Given this list of marker genes CHRNA4, CHRNB3, CHRNA1, CHRNA2, CHRNB4, CHRNA9, CHRNA6, CHRNB2, CHRNA5, CHRNA3, CHRNA7, here is a description of the gene set: Postsynaptic acetylcholine receptors mediate Ca2+ currents that may be involved in the facilitation of long term potentiation (LTP). species: Homo sapiens Reactome Pathway: Highly calcium permeable postsynaptic nicotinic acetylcholine receptors part of: Postsynaptic nicotinic acetylcholine receptors